Given this list of marker genes SRC, PIK3CB, AKT3, PIK3CA (NCBI Gene Id 5290), AKT1, AKT2, PGR, PIK3CD, here is a description of the gene set: Pathway Definition from KEGG: P4 -> (PGR+SRC) -> PI3K -> PIP3 -> AKT P4-PR-PI3K signaling pathway. Pathway ID: N01358. Pathway type: Reference. Pathway class: nt06214 PI3K signaling. Human Gene Set: KEGG_MEDICUS_REFERENCE_P4_PR_PI3K_SIGNALING_PATHWAY species: Homo sapiens